The following is a description of a gene set: species: Mus musculus from publication Yevshin I, Sharipov R, Kolmykov S, Kondrakhin Y, Kolpakov F (PMID 30445619) Mouse Gene Set: ZFP759_TARGET_GENES, and this is the list of marker genes: Oaz2, Phc1, Zbtb1, Zfp748, Lpin3, Wdr75, Tmod4 (NCBI Gene Id 50874), Lhfpl4, Nxph2, Cdx1, Camk1g, AI115009, Tfdp1, Tet1, Dbn1, Atp5f1d, Gm12740, Gm30835, Ptges3 (NCBI Gene Id 80424), 5730480H06Rik, Hmg20b, Cracr2b, Mettl8, Tmed2, Nme4, Tbl3, Gm6425, A330102I10Rik, Gm15708, Vcf2, Best4-ps, B4galnt3, Trp53cor1, Becn2, Dhx33, Nrl, Mir7673, Gm25489, Elovl5, Gm24068, Dnajc13, Pip4k2c, Pf4, Bcar3, Thap6, Arf4, Adam8, Vps72, Gm28874, Mpzl2 (NCBI Gene Id 14012), Tcf4, Lbhd1, Xpo1, Plcxd2, Atf6, Eva1c, Atg13, A630072M18Rik, Bnc1, Gpr68, Il15ra, Nr1h4, Kat2b, Rpl10-ps2, Gm4847, Gm14901, Evl, Cib2, Rnf135, Thap1 (THAP domain containing, apoptosis associated protein 1), Suv39h1, Raf1, Gm25184, Srebf1, Sulf1, Ltbp3, Strada, Mfap1b, Ccdc185, Rsrc2, Il23a (interleukin 23, alpha subunit p19), Gm16089, Mdk, Mir190b, Ube2r2, Snph, Ccdc28a, Ppard, Naprt, Pls3, Ccdc9, Tnpo3, Zbtb8a, Pla2g10, Eri3, Surf6, Acyp1, Aida, Gm2800, Phactr1, Cnbd2, Gpr107, Akr1b7, Gm9955, Mb, Gm14175, Atrip, Appl2, Gm13777, Rnf126, Lztr1, Mir654, Mgat5, Cenpk, Gm22973, Git2, Mir6365, Ube4b, Gm15821, Ctsm, Hsd3b7, Prrg4, Ttbk1, Gm26873, Enah, Zbtb25 (zinc finger and BTB domain containing 25), Gm26684, Mcph1, Rbm20, Tmem53, Gm7536, Carhsp1, Irf8, Shprh, Mog, Pdia3, Gpr35 (NCBI Gene Id 64095), Hmgcl, Ctsh, Tmem242, Slfn5, Gm29707, Gal3st1, Gm12924, Gemin2, Nipbl, Anapc1, Crppa, Gm24665, Zbtb39, Gm2174 (predicted gene 2174), Ncam2, Nmnat2, Fnbp4, Slc4a1, Spink8, Scarb1 (NCBI Gene Id 52288), 1700029H14Rik, Sertad2, Radx, Smpd1, Plet1os, Mrps17, F2, Mmp19 (matrix metallopeptidase 19), Ndufa10, Nts, Adh1, Ptprc, Gm36527, Jup, Ndufs4, Gm19261, Cfp, Mir7006, Mir6924, Tmprss5, Ankrd10, Spata16, P2rx7 (purinergic receptor P2X, ligand-gated ion channel, 7), Tns1, Entpd8 (ectonucleoside triphosphate diphosphohydrolase 8), Gcsh, Tfrc, Rigi, 4933406P04Rik, Pde4b, Mvd, Usb1, Smpd2, Lamp2, Nudt5, Sntb2, Peg12, Ern2, P2rx3, Gm13689, Taf4, Bola2, Frmd4b, Ly6g, Tor1aip1, Pcdhgc5, Sos1, Zhx3, Gm22272, Slc3a2, Tlr7, 4932412D23Rik, Stat5a, Myo15a, Ccr4, Gm23054, Vdr, Pdpr, Trcg1, Gm23723 (predicted gene, 23723), Mxra8, Cwh43, Ift140, Abcb9, Gm15651, Gm16261, Pfkfb1, Psma3, Hoxc9, Tmem132b, Nr0b2, Rffl, Myom3, Prpf38b, Rc3h1 (NCBI Gene Id 96936), Mfsd2b, Rragc, Slc39a2, Zfp512b, Dusp16, Alas1, Mphosph9, Pop1, Shc1, Zfp335os, Dlgap5, Fars2, Prickle4, Rasal2, Mecr, Hdac4, Parl, Lce3c, Extl1, Azi2, Rell1, Mir3097, Rwdd4a, Arhgap18, Gm16225, 1700120B22Rik, Rcbtb1, Zfp653, F830112A20Rik, Zfp106, Gm12333 (NCBI Gene Id 105244611), Arhgap27os1, Aff1, Gatad2a, Metrn, Slamf1, Gm26510, Myo18a, Emc3, Gckr, Gm12057, Smad7, Agfg2, Gm15197, Mat2b, Cfap45, Mbd5, Sptbn5, Gm14856, Fam186b, Runx2, Wdr17, Gm12620, Tal1, Slc36a4, Lyrm4, Bin2, Prkacb, Gripap1, Neu1, C330002G04Rik, Dgkz, Atg2a, Ctsa, Oscp1 (NCBI Gene Id 77181), Zfp867, Thumpd3, Ggnbp2, Gm10059, Gtf2i, Ikbkg, Bmp8b, Gm16519, Mir224, Gm28836, Gm25482, Arf5, Manba, Tyw1, Slc7a3, Zfp637, Ubtd2, Nckap1, Ribc2, Ccdc198, Mecomos (MDS1 and EVI1 complex locus, opposite strand, NCBI Gene Id 115489713), Nudt1 (nudix hydrolase 1), Gm24878, Slc30a2, Parp14, D030056L22Rik (RIKEN cDNA D030056L22 gene), Mrpl4, Slc38a8, Pknox1, 9430007M09Rik, Fam76a, Dnaaf9, Plbd2, Pom121, Dpep3, Dse, Znrf1, Ttf1, Gm11691, Tbc1d23, Mettl22, 2510002D24Rik, Gm12236, Btrc (beta-transducin repeat containing protein), Aste1, Abcg3, Mir8090, Impdh1, Cngb3, Prkab1, Cope, Ldha-ps2, Fkbp4, Onecut2, Mrpl14, Gm11191, Bltp3a, Sox15, Morf4l1, Zc2hc1a, Ino80d (NCBI Gene Id 329170), Atf7ip (activating transcription factor 7 interacting protein), AW047730, Hoxa11, Brca2, Xrcc2, 5830432E09Rik, Ppil2, Mir1199, Or2t43, Borcs5, Tulp3, Paqr8, Nmi, Pomgnt1, Myo1c, Fuca1, Chn1, Slc27a5, Trim67, Zfr, Prss54, Crb2, Ercc2, Sftpd, Platr27, Vcp, Xpnpep1, Fmn1, Usp10 (NCBI Gene Id 69204), Rad54l, Defb42, Gpr85, Oxct1as, Uso1, Kank3, Luc7l3, Diaph1, Srsf1, Mycbp2, Kcnmb4os2, Pitpnm2, Ltbp1, Tshz2, Hspa8, Parp10, 9330162B11Rik, Rps12-ps26, Doc2g, Gm11362, Dnajb2, Pik3ap1, Serpine2, Mir376a, Pglyrp3, Gm16084, Xrcc6, Mir5128, Gm26122, Cc2d2a, Dlk1, Sema4d, Rtl5, Ext1, Otx2, Ywhae, Hif1a, Hmgb1-rs16, Senp3, Timm17b, Actb, Gm15032, Pigm (NCBI Gene Id 98637), Ncoa3, Mttp, Esrp1, Pde9a, Phf24, Lgmn, Zfp82, Cyp2c70, Rpl30-ps6, Adamts8, Ube2h, Fgfr2, 4930532M18Rik, Ddx19a, Adamtsl2, Gm11771, 9430015G10Rik, Shroom1, Atp6v1e2 (NCBI Gene Id 74915), Insl6, Cass4, Slc36a3os, Rnf4, Ttc3, 9430024E24Rik, Gm26705, Tor1aip2, Csf1r, Creb3l2, Syne4, Golga2, Gm23706, Aatf, Mef2b, Slc44a1, C230066G23Rik, Gm14210, Tmem42 (transmembrane protein 42), Hepacam2, Fbxo27, Gm24696, 4930478M09Rik, Ppip5k1, Chchd2-ps, Cfap74, Ep300, Gm26049, Itgb1bp1, Runx1, Gnl3, Ccdc14, Pgd, 1110002J07Rik, Skida1, Mir7069, Polq, Dclk2, Lonrf2, Tldc2, Pole2, Acsl3, Rpl27rt, Slc35a4, Cdc42se2, Picalm, Map2k6, Peg13, Zbtb43 (zinc finger and BTB domain containing 43), Zfp319 (NCBI Gene Id 79233), Gm10069, 4930568G15Rik, Rpa2, Tgoln1, Nostrin, Fbxo36, Sbno1, Psma1, Man2a1, Ccl7, Egr4, Rpl35a-ps6, Mrps11 (NCBI Gene Id 97380), Rfwd3, Gm11665, Lrrc37, Nav2, Proca1, Yju2, Gm16166, Synj2, Rpl29, Serhl, Kat14, Arhgap26, Map6, Atcay, Faddos, Exoc3, Tkt, Gigyf2, Babam2, Gltpd2, Tle6, Crot, Eif1ad, 4930556N13Rik, Mkx, Emc8, Pik3r1, Fbxo28, Gm6736, Aspscr1, Gm10309, Glrx2, Rfx7, Fam83c, Drg1, Defb22, Gm6985, Spry4, Nabp2 (nucleic acid binding protein 2), Serpina10, Zic1, Acin1, Kcnd3os, Zfp142, Slc1a1, Slc12a6, Dhtkd1, Slc35a3, Unc13b, Gm5185, Lbr, Banp, Thpo, Zfp809, Amigo1, Tlk2 (tousled-like kinase 2 (Arabidopsis)), Clk2, Ldha, Gm22881, Supt5, Ptp4a2, Taf6l, Ufsp2, Il4, Mamstr, Ccdc191 (coiled-coil domain containing 191), Flad1, Maf, Usp19, Hes1, Gpr157, Teshl (NCBI Gene Id 69449), Fn1, Gm10531, Lifr, Mylpf, Anxa3, Adgrl3, Gm12403, Nsa2 (NSA2 ribosome biogenesis homolog), Gm13662, Sass6, Apom, Gm26885, Nsun5, Ash2l (NCBI Gene Id 23808), Gm26070, Supt6, Pif1, Celf1, Ttc19, Gm8398, Gm6397, Safb2, Pkdcc, Pou2f2, Eng, Gm8957, Tnks2, Rnpep, Sfrp1, Oas2, Gm19705, Map2k1, Ywhag, Copz2, Gm25224, Ctxnd2, Eif2d, n-R5s204, Gm9496, Ep400, Trim42, Septin9, Topors, Dkkl1, Ercc6 (NCBI Gene Id 319955), Hsph1, 4930505A04Rik, Siglecg, Hp1bp3, Ap2m1, Trp53i13, Slc25a30 (NCBI Gene Id 67554), Gm13110, Aktip, Gm16580, Phf20, Tpd52l2, Ascl4, Mms19, Dab2, Rcor2, Pde4d, Sergef, Gm20443, Kdm5b, Tomm20, Inpp5b, Zfp661, Tsga13, Gm13842, Immt, Tmem161a, Gm26019, Kifbp, Gm43772, Gamt, 2810432F15Rik, Acbd4, Ly6g6f, Rbm47, Uqcc4, Pbrm1, Rhbdl3, Rnf125, Gm24400, Smc1b, Nell1, Gm14491, Atp5mj, Gtf2h2, Gm3329, Mir6367, Iho1, Scin, Mroh1, Plekhs1, Mir7668, Msh3, Lcor, Adipor2, Ttc24, Actr8, Ly96, Srpk2, Oaz3, Jtb, Dars2, Rhbdl2, Phlpp2, Stap2, 1700003F12Rik, Gm25855, Kcnt2, Uba1, Poc1a, Cnga3, Egr3, Zdhhc6, Bcas1, Gm11271, Gc, Mpc1, Plekhg1, Cep95, Gdi2, Nabp1, S1pr4, Zwilch, Cerk, Fkbp7, Txnrd1, Hormad2, Zfp865, Specc1, Rtkn2, Stag3, Gpr45, Hlcs, Rbms3, Gm12269, Gm16548, Mzf1, A930018P22Rik, Pdzd9, Gm12803, Mc2r, Zan, Cradd, Fbrsl1, Sp1 (NCBI Gene Id 68485), Gm12610, Taf1c, Gm12516, Mad2l1, Gm26207, Csde1 (NCBI Gene Id 99530), C030013C21Rik, G6pc3, Sag, Oaz2-ps, Lmo7, Gm4961, 1700120K04Rik, Tns3, Gm12393, Rbm41, Tubgcp3, Adck2, Mir376b, Samd10, Pigh, 1500012K07Rik, Kash5, Snx1, Psmb3, Dpysl5, Gm24461, Senp6, Caml, Alg11, Slc6a4, Sv2b, Cd36, Tbx3, Krt15, Cp, Tsg101, Bcl2l12, Rgs16, Gm26725, Slc7a11, Gm13561, Fam171b, Dnah2, Tanc1, Gpc2, Psph, Vmn1r-ps149, Rhd (NCBI Gene Id 57768), 1700093K21Rik, Map4, Mir370, Defb47, Mpnd, 2310010J17Rik, Dync1h1, Lat2, Gabra2, Ficd, Chfr, Fkbp14, Shroom3, Tenm4, Cryl1, Jph4, Nsmaf, Rnf6, Setx, Cfh, Meis1, Hsd11b1, Sp2, Zdhhc15, Kcnh8, Magohb, Nhsl2, Tmem202, Zfp574, Gm25217, Car7, Med18 (NCBI Gene Id 67219), C2cd6, Kdm5c, Mir129-2, 2310011J03Rik, Gm30648, Fam161b, Tmeff2, Gse1, Wfs1, Lars1, Nhp2, 2410002F23Rik, Gm38165, Oplah, Mir3618, Tenm2, Atxn2, Prrc2c, Ankzf1, Gm7299, Ino80dos, Gm15039, Gm15413, Alms1, Cdh13, Nrdc, Lyl1, Mir3108, Traj1, Xpnpep2, Sptb, Atp5f1b, Gm12464, Cdc23, Gm30292 (NCBI Gene Id 102632139), Gm11775, Spag5, Ogt, Kctd3, Mir6915, Sun1, Xab2, Pierce2, Btbd18, Acad9, Zfp961, Fbxl20, Rwdd2a, Ech1, C9orf72, Lingo4, Zfp788, Gm11637, Helz, Cbfb, Gm15328, Nrxn1, Gm37885, Dyrk4, Gm42799, Piwil1, Gapvd1, Fam216a, En1, Jakmip1, Tom1l1, Papss2, Ikbke, Kit, Triap1, Fmc1, Zfp395, Sarm1, Glrx5, Zfp975, Arhgef16, Rapgef6, Gm6673, Gm14987, Stpg3, Wipf1, Farsa (phenylalanyl-tRNA synthetase, alpha subunit), Mir300, Gm7928, Myo1g, Ammecr1, Matn3, Habp2, Sdf2, Gm24469, Nbr1, Dnmt3a, Rbp7, Sox4, Slc25a18, Bex6, Ptch1 (NCBI Gene Id 77214), Tcea2, Prkag2, Caps2, Tra2a, 4930517L18Rik, C1galt1, Mien1, Virma, Gm15515, Plekhg5, Pzp, Plppr1, Bclaf3, Treml4, Cyp4a28-ps (cytochrome P450, family 4, subfamily a, polypeptide 28, pseudogene), A530064N14Rik, Gm12980 (NCBI Gene Id 100039588), Slc18a3, Ipo11 (importin 11), Garre1, Rrp7a, Atp8b4, 2900092N22Rik, Adhfe1, Nr2f6, Setdb2, Gm12313, Fzd7, Maea, Otud4, Gm24435, Edrf1, Leo1, Ptpn11, Tgfbr2, 4930444P10Rik, 5430405H02Rik, Ninj2, Zbtb34, Smtn, Papola, Ccndbp1, Gtf3c2, Rps15a-ps8, Gm25364, Fxr2, Bdh2, Cntnap2, Prom1, Mfsd14b, 2610206C17Rik, Top3b, Efcab14, Iqce, Rhot1, Gm12308, Cpsf4, Gm2474, Or6n1, Kif5b, Rbbp6, Agap1, Fgfr1, Zcwpw2, Uvrag (UV radiation resistance associated gene), Gm4918, Mir142, Vmp1, Apoe, Ppfibp2, Itgbl1, 2700099C18Rik, Mrm2, Pcdhb18 (NCBI Gene Id 93889), Gm25744, Gm20257, H4c6, Prrc2a (proline-rich coiled-coil 2A), Ube2d1, Gm26560, Ssc4d, Yeats2, Exosc2, Tmem199, Mir7035 (NCBI Gene Id 102465626, microRNA 7035), Tm4sf5, Gm25439, Aldh7a1, Brd1, Rrm2b, Pold2, Klf1, Ppp1r8, Arl3, Ngp, Kcnip2, Timeless, Gm23347, Atrn (attractin), St6galnac2, Homer1, Gm37116, Bag5, B130024G19Rik, Smagp, Cln3, Hhip, Rpl38, Myo3a, Ptpn3, Eif2b3, Itgb5 (integrin beta 5), Mir7675, Gcnt7, Vwf, Gm26795, Sirt7, Capn11, Catsperb, Faiml, Gm24888, Gm25785, Top3a, Gm17806, Gm9887, Gng7, Nup160, Arl2bp, Cars1, Cers2, St7, Tnik, Rad51c, Ralgps2, Prcc, Bmal1, Gm23123, Ncoa4, Mir770, Zmiz2, Jak1, 4930509H03Rik, B4galt6, Gm11475, Phex, 4933408N05Rik, Mns1, Kntc1, Gm12271, Gm12608, Trim36, Src, Trip12, Noxred1, Uckl1, Gm5764, Has2os, Xpnpep3, Btbd19, Sspn, Gm24066 (NCBI Gene Id 115485871), Hspa4, Atxn1l, Abhd5, Gm25862, Terf2, Lonp2, Fam131a, Zmynd12, Clec2d, Slc12a3, Slain1, Nadk2, Gm15806 (NCBI Gene Id 100417786), Med6, Apobec1, Igfbp4, Taf3, Rfx2, Or6c8, Klf13, Mir1306, Scube3, Gm5248, Ess2, Calcoco2, Gm12653, Ext2, Elk4, Cd101, Rabep2, Olig3, Elp5, Hmx1, Gm8186, Trerf1, Gm9599, Uba5, Xpr1, Ino80c, Dlg3, 0610040F04Rik, Pik3cd, Raver2, Rtl1, Arhgef7, Metap2 (NCBI Gene Id 78359), Stra6, Cxxc1, Nfkbiz, Copg2, Fcnaos, Ubxn1, Lzts3, 0610043K17Rik, Eif5al3-ps, Gm5302, Srrm1 (NCBI Gene Id 99965), Ddx27, Ntpcr, Rsph14, Pomp, Chrna9, Gm12828, Ppp4r4, Ski, Rgs3, Cep131, Atp7a, Eef1a1, Safb, Gm15550 (NCBI Gene Id 675794, predicted gene 15550), Gm4915, Mto1, Dph2, H4c16, Cdh5 (NCBI Gene Id 12562), Uhrf1, Plekha5, Pdgfd, Acat1, Gm5532, 1700023H06Rik, 4930526A20Rik, Pask, Rian, Dennd2a, Tnfrsf1a, Cep85, Ugt1a9, Islr (NCBI Gene Id 26968), Gm23382, Opcml, Gm34248, Nadsyn1, Gm10532, Ints10, Strc, Entpd1, Sel1l3 (sel-1 suppressor of lin-12-like 3 (C. elegans)), Cirbp, Fcgr3, Ambra1, Pcmt1, Hlx, Cnppd1, Hspa9, Il2ra, Runx3, Pacrg, Frmd8, Kcnk12, Arhgdib, Ppp1r9b (NCBI Gene Id 217124), Gm12125, Fam193a, Adat1, Tmem248, Tcf7, Cars2, Slc25a38, Lamc2, Usp14, Uggt1, Arrdc3, Gm26176, Trim8, Snhg7os, Or2w25, Stox2, Erc1, Gli2, Uqcrc2, Gm12687, Cltc, Fhip2b, Tet3, Zfp568, Nbdy, Fscn1, Sec14l5, Rgs12, Glra2, Msx2, Zfhx4, Pakap, Pdlim5, Ddr1, Mfge8, Fastkd5, Fam219b, Samsn1, Defb40, Gm12848, Fbxl22, Pold3, Arhgef2, Rbm25, Itpa, Ankrd1, Ankdd1a, Gm11379, Gm24989, Plin1, Psme2, Tmem131l (NCBI Gene Id 229473, transmembrane 131 like), Vps39 (VPS39 HOPS complex subunit), Ubd (ubiquitin D), Shox2, Actl6b, Exosc1, Efna3, Amz1, Zfp426, Gm19815, Wif1 (Wnt inhibitory factor 1), Snrnp200, Gm973, Ccsap, B4galt7, Fam98c, Gm8213, Satb1, Hipk1, Zc3h12b, Zfp64, Sez6, Setd2 (SET domain containing 2), Zfp866, Gm8421 (predicted gene 8421), D030068K23Rik, Phip (pleckstrin homology domain interacting protein), Plcd4, Slc2a9, Vpreb1a, Tekt5, Or7c74, Cnot3, Gm15222, Smco4, Gm12091, Ints5, Mroh7, Gm40309, Gm8849, Dnajc17, Ddx23, Samd1, C2cd5, Ssr2, Gm15266, Prss40, Atp6v1e1, Elavl4, Krtap20-2, Arpc5l, Ccdc17, Tle3, 1700109H08Rik, Abcc3, Selplg, Bcat2, Ruvbl1, Mtfr1, Lag3, Pdlim1 (PDZ and LIM domain 1 (elfin)), Ywhaq, Ube2k, Sp5, Bcl11b (NCBI Gene Id 78682), Nasp (nuclear autoantigenic sperm protein (histone-binding)), Eci1, Nktr, Akap1, Pi4ka, Pdlim2, Phb1, Abo, Mrpl9, Atpaf1, Camk1, Pdk1, Fads6, Kcnab2, Plekhb1, Niban3, Ccdc170, Mcm3ap, Lalba, Csnk1g3, Ahctf1, Slc39a1-ps, Tjp3, Nf1, Zbtb7a, Mpped1, Lst1, Or1p1c, Dpp4, Gm7097, Tmem61, Mettl21c, Vps4a, Gm3830, Bcl7b, Sqstm1, Abca16, Mxd3, Snf8, Slco1c1, Dpp6, Gm13180, Tpd52, Mecom, Utp6, Lgals9, Ighg1, Pigx, Rassf9, Tpk1, Erg, C5ar2, C1qtnf1, Or10ad1c, Thoc2l, Scn3a, Mrpl22, Akirin2, Vac14, Ptbp1, Etv5, Tnfaip2, Elapor1, Klhl22, Taldo1, Rplp2, Meg3, Gm24141, Anapc15 (NCBI Gene Id 75430), Hecw2, Mov10l1, Znfx1, Gm12855, 4930447F24Rik, Tdrd9, Gm4349, Rad54l2, Supt7l, Slc12a5, Gm13529, Ephb6, Rtn4, Ehmt2, Pkd2l1, Gm12492, Coq10b, Nova1, Slc25a19, Nrde2, Zfta, Tbc1d14, Dll1, Eya3, Gm6872, Shkbp1, Tmem200a, Aloxe3, Ankrd40, Bcas2, Adarb1, Tle2, Gm13197, Pde8a, Gm13916, Bnip1, Ahcyl2 (S-adenosylhomocysteine hydrolase-like 2), Snta1 (syntrophin, acidic 1), Fancd2, Gm9929, Hmgb1, Kmt2d, Prkcb, Fcf1, Nek9, Gfod2, Kcnt1, Gm24296, Frat1, Kdm5a, Gfer, Afap1, Cib1, 5031434O11Rik, 4921511C10Rik, Mrpl21, Cdr2l, Gcn1, Srd5a3, Arl13a, Gm2990, St13, Ubald1, Gga2, Myo5b, Rpl14-ps1, B3gat1, Map6d1, Rdm1, Kif3a, Kcnj16, 4930515G01Rik, Klk8, 1700022A21Rik, Rab3gap1 (RAB3 GTPase activating protein subunit 1, NCBI Gene Id 69346), Rhbdd2 (rhomboid domain containing 2), Zfp212, Gm12886, Limk2, Tmem231, Cenpo, Gm14162, Ndufa12-ps, Chd2, Gm4784 (NCBI Gene Id 213474), Lmf2, Gm4128, 4930533L02Rik, Grm1, Trmt61a, Dcbld2, Dixdc1, Pan3, Gna11 (guanine nucleotide binding protein, alpha 11), Gm13489, Phyh, Stip1 (stress-induced phosphoprotein 1), Gm24452, Slc25a36, Hs3st3a1, Mlkl, Garnl3, Ing3, Mcf2l (mcf.2 transforming sequence-like), Gm15610, Nectin3, Eva1b, 4931406C07Rik, Mageb18, Dnm2, Agpat2, Usp3, Tfap4, Kcnk6, Tma7, Gm11736, Pcdhgb8, Gm5258, Pfdn5, Inpp5k, Park7, Ociad1, Thrap3 (NCBI Gene Id 320018), Magi2, Myo10, Psmd2, C630004M23Rik, Gm10829, Clec2l, Mir3475, Gm12467 (predicted gene 12467), Rpl22, Ophn1, Prss43, Ppip5k2, Gm7094, Celf2, Gm23605, Pick1, Auts2, Lgals4, Ttc13, Vgll4, Ptp4a1, 9230104M06Rik, Acot11, BC050972, Osbpl7, Dhx30 (DExH-box helicase 30), Dlat, Igf1r, Pramel7, Mir7238, Ddx60, Gm5865, Limch1, Rbm6, Ubap2, Smim14, Naa12, Nbeal2, P4ha2, Hsp90ab1, D830032E09Rik, Clasp1, Plaa, Socs2 (suppressor of cytokine signaling 2), Slc1a2, Lum, Kcns1, Cdc25a, Adal, Pou2f1, Zfp318, Sigmar1, Adamts1, Fbxo42, Gm25261, Ppp2r5c, Gm7993 (predicted gene 7993), Slc22a19, Plcb2, Nkx1-2, Pwwp3a, Casp8, Pkp4, Sipa1, Wdr95, Pigs, 1110038B12Rik, Cadm2, Fau-ps2, Gm22764, Prss36, A830035A12Rik, Axl, Atp8b3, Nedd4, Rapgef4, Vamp1, Eda2r, Gm23479, Slc7a7, 1700101I11Rik, Phf6, Stk38l, Prc1, Rtp3, Clcn7, Nrm, Hars2, Casp8ap2, Gpr84, Smg7, Ralbp1, Chrna10, Dus3l, Slc25a53, Matr3, Npr3, Vdac1, 6430548M08Rik, Trim34a, Akr1a1, Sertad1, Prpf38a, Mgst2, 9530068E07Rik, Platr22, Mmachc, Txnrd2, Ift81 (NCBI Gene Id 12589), Atp6v0d1, Zfp7, Crybg2, Tifab, Tsc22d4, Ubtf, Dbpht2, Ntan1, Zfp36l1, Gm25402, Itih3, Cpeb3, Fbll1, Slc22a7, Slc2a3, Degs2, Stx3, Fbln2, Dimt1, Ciapin1, Emc10, Tmem266, Mamdc4, Rnaseh2a, Rbm5, Gm6365, Mir103-2, Uba2, Sptan1, Fgd5, Cse1l, Ifna13, Cyb5r3 (NCBI Gene Id 97979), Ccdc121rt2, Atp23, Patj, Kazald1, Sapcd2, Znhit3, Cblc, Asl, Ube2f, Palld, Hivep3, Rsu1 (NCBI Gene Id 20163), Mrtfa, Gm42161, Mrpl28, Cdkn1a, Znrf4, Ksr1, Klhdc2, Rps12-ps7 (NCBI Gene Id 670421), Cyb5r1, Snhg17, Tcp1, Nek2, Nkain1, Taf1d, Mpi, Scrn2, Mapkbp1 (mitogen-activated protein kinase binding protein 1), Cyp4f15, Snrnp25, Serpinc1, Cited2, Sinhcaf, Hapstr1, Tef, Stradb, Aldoa, Zfp27, Tmem131, Atp8b2, Adig, Myh13, Mir7057, Ift70a1, Otx2os1, Timp4, Dtnb, Aifm3, Gm43522, Or10ad1, Gm20544, Rasa3, Sfmbt2, Zfp438, Gm11444, Gstp2, Gm27811, Arfgef1, Zdhhc5, Ndel1, Zfp512, 9130230L23Rik, Cfap47, Rabl6, Aunip, Mir3965, Gm24592, Ctnna3, Tatdn2, Fam234a, Ptrh2, Mir17hg, Ndfip2 (Nedd4 family interacting protein 2), Adamts2, Ube2d2a, Lcn12, Acad11, Cd9, Sptbn2, Pdcd6ip, Ccdc163, Chtop, Shf, Gm23502, Nrbp1, Prrt1b, Gm14095, Or2c1, Csdc2, Arl15, Ift122 (NCBI Gene Id 97320), Gm12339, Gm29718, Gadd45gip1, Tgif1, Taar9, Nicn1, E130018O15Rik, Gm5424, Fanca, Tmco2, Gm4577, Catsper2, Or1a7-ps1, Myg1, Hapln1, Zfat, Gm15770, Rex1bd, Pgap2, Snord52, Ift46, Trafd1, Gm5432, Lrriq4, Gm11548, Gaa, Hexd, Bltp2, Tamm41, Tnfaip6, Wdfy3, Med1, Dgcr8, Ctcf, Gm25894 (NCBI Gene Id 115489084), Zfp747l1, Irf3, Anxa7, Lrp2, Gm7069 (NCBI Gene Id 631594), Mir7075, Tomm34, Mir152, Nr1i3, Misp3, Crnde, Rad1, Cngb1, Arhgap4, Grin3b, Mrpl30, A230083N12Rik, Kcnq5, Crb3, 1700008O03Rik, Wnk1, Gm12654, Rsf1, Sh3kbp1, Nr6a1, Gm23508, Zcchc8, Hint1, Ttc29, Sla, Angel1, Nr6a1os, Zfp521, Kcnv2, Gfi1b, Hnrnpr, Gak, Pcdhb22, Trpm1, Stard8, Il17rd, Gadd45g, Dnajc11, Gm6633, Glis3, Acsbg3, Pgpep1l, Nepn, Foxk1, Rnf115, 1700025G04Rik, Echs1, Srpk1, Nrg4 (NCBI Gene Id 83961), Dst, Spcs1, Pcdh19, Flvcr1, Lrrc42, Gng10, Cdc42ep1, Zpld1, Mllt10, Deup1, Gm10729, Cux1, Rab43, Gm37053, Uts2r, Adamts19, Scpep1, Scn9a, Nfe2, Pus1, Atp5f1a, Mdc1, Gm20619, Epha10, Gas8, C030037F17Rik, Rbm22, Cckar, Ddx52, Sec16a, Ifng, Mast1, Akr7a5, Selenof (selenoprotein F), Pdzd2, Glb1l, Psmd7, Mgat4a, Crem, Misp, Serpinb6e, Dhcr7, Traf3ip1, Tbc1d9b, Cfap69, Agap3, Txndc9, Tbx3os1, Zp1, Gm6366, Mindy1, Sephs1, Mir376c, Rogdi, Faim2, Sumf2, Ssbp4, Golga5, Pds5a, Gm11657, Sfi1, Rph3a, Chd8, Hoxa11os, Baz1b, Gm13954, Apex2, Nsf, Gm14111, Cacnb4, R3hdm2, Fus, Adamts6, Hook1, Sgip1 (NCBI Gene Id 73094), Rabgap1l, Tex14, 5830487J09Rik (RIKEN cDNA 5830487J09 gene), Cacna1a, 2810407A14Rik, Bmx, Gm13207, Zfp790, Foxp1, Acsbg2, Rgs11, Tango2, Mdm4, Qtrt2 (queuine tRNA-ribosyltransferase accessory subunit 2), Shmt1, Psmc1, Gm9506, Dnajc1, Gm22972, Gm16096, Plekha6, Vmn1r193, Pisd-ps1, Myom2, Aurka, Dsc1, Rab27a, Lhfpl6, Pou6f1, Ttf2, Psmd4, Tulp1, Oser1, Mfap2, Brix1, Uba52, 4933440N22Rik, Rnf20, Gm11197, Usp1, Mir6385, Gm23090, Gm16342, Heatr5b, Rprd2, Plxnd1, Sardh, Rtf2, Utp25, Gm11462, Ctbp2, H2-M5, Hmgxb4, Zfp609, Pax6, Gm25369, Ppfia1, AA986860, Phox2b, Ddx20, Gatm, Tspan17, Lcmt2, Slc1a3, Mlxip, Pnpla7, Fcna, Mdfic2 (NCBI Gene Id 330390), Adgrg5, Snora17 (NCBI Gene Id 100306954), Kptn, Azin2, Zdhhc8, Gm49316 (NCBI Gene Id 102632793), Birc6, Rai1, Scd4, Phf21a, Mbtps2, Ubtfl1, Gnl3l (guanine nucleotide binding protein nucleolar 3 like), Gm8022, Ehbp1, Gm23407, Cenpi, A830031A19Rik, Mkln1, Clstn3, Ckap2, Ttc39c, Eif4e2